Given this list of marker genes RACK1, RPS2, TOM1, ACO2, H2AX, NUCB1, H2BC7, EIF3G, RALY, TYMP, SLURP1, GPI, here is a description of the gene set: To gain insight into the transformation of epidermal cells into squamous carcinoma cells (SCC), we compared the response to ultraviolet B radiation (UVB) of normal human epidermal keratinocytes (NHEK) versus their transformed counterpart, SCC, using biological and molecular profiling. DNA microarray analyses (Affymetrix), approximately genes) indicated that the major group of upregulated genes in keratinocytes fall into three categories: (i). antiapoptotic and cell survival factors, including chemokines of the CXC/CC subfamilies (e.g. IL-8, GRO-1, -2, -3, SCYA20), growth factors (e.g. HB-EGF, CTGF, INSL-4), and proinflammatory mediators (e.g. COX-2, S100A9), (ii). DNA repair-related genes (e.g. GADD45, ERCC, BTG-1, Histones), and (iii). ECM proteases (MMP-1, -10). The major downregulated genes are DeltaNp63 and PUMILIO, two potential markers for the maintenance of keratinocyte stem cells. NHEK were found to be more resistant than SCC to UVB-induced apoptosis and this resistance was mainly because of the protection from cell death by secreted survival factors, since it can be transferred from NHEK to SCC cultures by the conditioned medium. Whereas the response of keratinocytes to UVB involved regulation of key checkpoint genes (p53, MDM2, p21(Cip1), DeltaNp63), as well as antiapoptotic and DNA repair-related genes - no or little regulation of these genes was observed in SCC. The effect of UVB on NHEK and SCC resulted in upregulation of 251 and genes, respectively, and downregulation of genes in NHEK and genes in SCC. To further analyse these changes, we used a novel unsupervised coupled two-way clustering method that allowed the identification of groups of genes that clearly partitioned keratinocytes from SCC, including a group of genes whose constitutive expression levels were similar before UVB. This allowed the identification of discriminating genes not otherwise revealed by simple static comparison in the absence of UVB irradiation. The implication of the changes in gene profile in keratinocytes for epithelial cancer is discussed. from publication Dazard JE, Gal H, Amariglio N, Rechavi G, Domany E, Givol D (PMID 12771951) Cluster G5: genes up-regulated in NHEK cells (normal keratinocyte) at 3 h and 24 h time points after UV-B irradiation. studied in species Homo sapiens Human Gene Set: DAZARD_UV_RESPONSE_CLUSTER_G5